Given this list of marker genes USP34, PRTFDC1, CPA3, NUDT12, SLC24A3, ZCCHC14, MAPT, IQCK, DEGS1, CCDC47, DUS4L, PHC2, SYT2, SLC37A2, UBR3, SIM2, USP12, RBM46 (NCBI Gene Id 166863), HOMEZ, ARID3B, EPOR, SMAD2, PRDM6, POGZ, MOCS2, GAB2, MYF5, PRX, TANC1, ALMS1, HMGA2, here is a description of the gene set: Genes predicted to be targets of miRBase v22 microRNA hsa-miR-365b-5p in miRDB v6.0 with MirTarget v4 prediction scores > 80 (high confidence targets). Human Gene Set: MIR365B_5P species: Homo sapiens from publication Chen Y, Wang X (PMID 31504780)